Given this list of marker genes Clock, Ddr2, Cul4a, Tcf3, Ing4, Nek1, Stxbp4, Iqgap3, Tacc3, Btn2a2, Aurka, Gli1, Rassf1, Adam17, Nop53, Rpa2, Ecd, Dpf2, Prap1 (NCBI Gene Id 22264), Pias1, Trp53bp1, Cdk1, D1Pas1, Cdc14a, Bcl2, Tert, Trrap, Fancd2, Ambra1, Cdk5, Tm4sf5, Npat, Dna2, Cdc5lrt1, Ctdsp1, Cks1b, Chmp7, Usp28, Cyp1a1, Smarce1, Akap8, Rnaseh2b, Setmar, Tmod3, Prpf4b, Cdc7, Hspa8, Mus81, Rpl24, Rb1, Nsmce2, Mnat1, Akt1, Anapc1, Cdc5lrt4 (NCBI Gene Id 668191), Actl6b, Arhgap33os, Smarcd1, Cdkn2d, Abraxas1, Tbx1, Rcc2, Stk35, Pcid2, Rfwd3, Nek6, Tipin, Tti1 (NCBI Gene Id 98972), Cirbp, Hinfp, Npm2, Bub1 (NCBI Gene Id 99145), Dbf4, Itgb1, Rpl17, Brd7 (NCBI Gene Id 27017), Ik, Npm1, Rgcc, Ankrd17, Taok1, Nes, Knl1, Rhno1, Ccna1, Pdik1l, Cdca5 (cell division cycle associated 5), Chmp4b, Crlf3, Ccnb1-ps, Khdc3, Dyrk3, Ptprv, Brsk1, Vps4a, Rad51b, Prkcq, Cdc20, Cdca8, Psmg2, Cdc5lrt5, Cdk5rap3, Taf2, Cdkn2c, Mir124a-3, Mdc1, Cdc25b, Bcl7a, Ccl12, Ube2srt, Anapc2, Cdc14b, Tiprl, Tpr, Tmsb4x, Zc3h12d, Phf10, Mad2l1, Tcf19, Ier3, Atm, Rbbp8, Mblac1, Kcna5, Anapc15-ps (anaphase promoting complex C subunit 15, pseudogene), Cdk6, Rhou (NCBI Gene Id 69581), Trp63, Psme3, Prox1, Ptpn6, Lyn, Adamts1, Apex1, Mapk14, Cdc6, Nae1, Stil, Mos, Macroh2a1, Ercc3, Atad5, Mir26a-1, Nsun2, Susd2, Uimc1, E2f6, Mad1l1, Topbp1, Dtx3l, Klhl18, Ccna2, Cdk16, Pten (NCBI Gene Id 70161), Abcb1a, Ubd, E2f4, Hormad1, Eif4g1, Trex1, Mn1, App, Fbxo7, Anapc5, Six3, Miip, Cdc23, Id2, Skp2, Eif4ebp1, Nfix, Nfib, Eme2, Kif14, Apbb2, Mbtps1, E2f5, Ccne2, Anapc7, Bid, Brca2, Xpc, Dbx2, Rad9b, Tjp3, Dgkz, Tex14, Rrm1, Trip13, Plk1, Larp7, Camk2a, Ercc6, Cdk2, Ptpn11, Pkp3, Cdc25c, Spc25, Acvr1b, Fbxo5, Crebbp, Usp29, Ube2c, Nabp1, Mre11a, Rad51, Etaa1, Pbx1, E2f3, Dpf1, Cul3, Plk5, D7Ertd443e, Sde2, Kntc1, Lsm10, Ppp2ca, Nek10, Foxm1, Ppp2r3d, Usp26, Ccnd1, Eme1, Myc, Nuf2, Pim2, Cdk2ap2, Rrm2, E2f7, Cdc5l, Cdkn2a, Pkd1 (polycystin 1, transient receptor potential channel interacting), Psme1, Lats2, Gigyf2, Fbxo4, Cenpj, Ndc80, Clasp2, Ppm1d, Cit, Syf2, Zfp207, Calm3, Cdc5lrt9, Cul4b, Hsf1, Cenpe, Zfp36l1 (NCBI Gene Id 78714), Fbxl15, Mapk15, Kcnh5, Atp2b4, Smarcc2, Usp17le, Pdpn, Plcg2, Lcmt1, Ccnf, Ccnd3, Tfap4, Brcc3dc, Wac, Ccnj, Wnt10b, Neurog1, Mta3, Anxa1, Fbxo31, Smarca4, Ezh2, Ctdsp2, Fhl1, Zfp830, Fam83d, Cpsf3, Bard1, Sin3a, Rbl2, Trim71, Hus1, Babam1, Fzr1, Mbtps2, Mettl13, Cdkn2b, Atf5, Kank2, Ctdp1, Usp50, Mrnip, Zfy2, Prpf19, Camk2d, Rad1, Gnb1l, Rps6, Stk38, Gpnmb, Smarcc1, Hecw2, Spast, Ube2a, Ccnd2, Appl1, Rdx, Fgf10, Plrg1, Taok2, Taok3, Crnn, Ube2l3 (NCBI Gene Id 98018), Cdk10, Lmnb1, Ddb1 (NCBI Gene Id 13194), Clspn, Pinx1, Mir26a-2, Phf8, Fbxl7, Usp37, Dot1l, Rab11a, Ercc2, Arid1a (NCBI Gene Id 93760), Cdkn1c, Prkdc, Ccne1, Cep63, Tpra1, Gen1, Ccny, Ovol1, Cry1, Blm, Ccdc57, Cdc5lrt7, Aurkb (NCBI Gene Id 20877), Ccar2, Eps8, Mtbp, Rad17, Lats1, Cdc5lrt10, Cks2, Dpf3, Smarcd3, Dtl, Bcl7c, Plcb1, Rint1, Cdc5lrt6, Pkia, Id4, Rad51c, E2f1 (E2F transcription factor 1), Acvr1, Rad21, Ccnb3, Arpp19, Ccng2, Chek2, Cep192, Ppp1r10, Ppp6c, Ccno, Usp44, Stox1, Rps27l, Ensa, Wdr76, Sass6, Ccng1, Tfdp1, Smc5, Kat14, Pkmyt1, Nfia, Tgfb1, Vps4b, Ints7, Nasp, Cdc27, Cdk4, Mir26b, Cenpf, Zwilch, Atr, Ska3, Dcun1d3, Cdk18, Ube2s, Trp53, Rcc1, Fam107a, Apbb3, Men1, Ctdspl, Rad9a, Hus1b, Ube2e2, Spdl1, Eif2ak4, Smarcd2, Zfp36l2, Spdya, Bub3, Mastl, Cdc73, Bcl7b, Hyal1, Bub1b, Klf4, Ccnjl, Cables1, Anp32b, Dusp1, Paf1, Haspin (NCBI Gene Id 14841), Ska1, Appl2, Ube2u, Hacd1, Ccnb2, Birc5, Pkd2, Cdk15, Ppp2r2d, Rad50, Psme2, Ptprc, Klhl22, Actb, Mad2l1bp, Ccnh, Foxn3, Foxo4, Egfr, Mbd4, Abcb1b, Apc, Spc24, Riok2, Prmt2, Brsk2, Actl6a, Timeless, Chmp2a, Diaph3, Fem1b, Senp2, Usp22, Cacul1, Brd4, Kmt2e, Ino80, Cdk7, Cdk17, Plpp2, Plk2, Pabir1, Ccnq, Anapc4, Eif4e, Mepce, Zw10, Slfn1, Chek1, Cdk5rap2, Brcc3, Msh2, Cdc5lrt8, Plk3, Cdk3, Zwint, Ufl1, Map3k20, Aven, Nabp2, Tcim, Inhba, Chfr, Nek11, Babam2, Jade1, Mlf1, Mir124a-1, Calm1, Cdkn1b, Smarca2 (SWI/SNF related, matrix associated, actin dependent regulator of chromatin, subfamily a, member 2), Trim39, Wee1 (WEE 1 homolog 1 (S. pombe)), Atf2, Phb2, Clasp1, Ush1c, Sox2, Ticrr, Brca1, Pagr1a (PAXIP1 associated glutamate rich protein 1A), Dact1, Gpr15lg, Lsm11, Rptor, Pbrm1, Apbb1, Donson, Csf1r, Aif1, Gjc2, Cdc16, Rbl1, Ttk, Myb, Inip, Cdt1, Myo16, Ints3, Ppp3ca, H2ax, Tpd52l1, Stk33, Klf11, Camk2b, Ccnb1, Rps6kb1, Dlg1, Mdm2, Kdm8, Parp9, Taf10, Calm2, Hspa2 (NCBI Gene Id 15512), Anapc11, Mir124a-2, Incenp, Usp47, Gas1, Akap8l, Gpr132, Zfyve19, Anapc15, Tbx2, Map3k11, Xrcc3, Pole, Paxip1, Arid2, Cdc25a, Upf1, Nbn, Ccni, Orc1, Cdk14, Camk2g, Cacnb4, Atrip, Ctc1, Chmp4c, Dync1li1, Cdkn1a, Smarcb1, AY074887, Zfp655, Bmyc, Rrm2b, Creb3l1, Ddx3x, Nfatc1, here is a description of the gene set: Mouse Gene Set: GOBP_CELL_CYCLE_PHASE_TRANSITION The cell cycle process by which a cell commits to entering the next cell cycle phase. studied in species Mus musculus